Given this list of marker genes NEK9, TP63, ANTXR2, SEC24C, WAS, TBX1, TTC7A, WIPF1, KMT2D, POLR1B, RAG1, RORC, ARVCF, PLXND1, AK2, POLR1D, ADA, CHD7, POLR3A, TBX2, POLD3, FREM2, RREB1, RAG2, UFD1, MCM10, FOXN1, NKX2-6, PEX5 (peroxisomal biogenesis factor 5), ATM, HIRA, SKIC2 (NCBI Gene Id 6499), POLR1C, IL2RG, LTBP4, SKIC3, NSMCE3, COMT, PI4KA, TCOF1, JMJD1C, ORAI1 (NCBI Gene Id 84876), G6PC3, DCLRE1C, GP1BB, here is a description of the gene set: Human Gene Set: HP_APLASIA_HYPOPLASIA_OF_THE_THYMUS Aplasia/Hypoplasia of the thymus species: Homo sapiens Absence or underdevelopment of the thymus.